Given this list of marker genes CTNNA1, SH2D1A, AHCYL2, NABP1, DCLRE1C, MTCL2, GRM8, GFM2, HAPSTR1, CDK15, HOXA9, P2RY12, GNRHR, PAWR, IBTK, SMURF1, FAM217A, CPSF6, FOXA1 (NCBI Gene Id 3169), EMX2, GRID2, TJP1, PLEKHB2, MIDEAS, NFIB, ZBTB18, NAP1L1, RNF138, DNAJC21, CBLN2, FNIP2, SLC25A35, NTS, TMEM215, WAC, ZMYND8, VAV3, ALKBH8, DTX3L, IL1A, GUCY1A2, GNPDA1, CLK4, CCND3, PRDX3, TET1, SH3RF1 (SH3 domain containing ring finger 1), MAGEE1, COQ9, STRIP1, GPR12, KLHL31 (kelch like family member 31), MBOAT1, FAM169A, ACVR2A, USO1, MCFD2, VHLL, ETAA1, ZNF491, ELOVL5, DNAAF9, ZNF677, RPL31, MED13, SOD2, CYBRD1, BEND6, TFG, PCDH19, CLSPN, SUDS3, CA5A, SMG1, MINAR1, LAMP5, SS18, C1orf52, MAP3K9, FNDC3B, SLC35B4, COL11A2, ATP2C1, TMEM68, INSIG1, RAD51B, BRINP2, FAM76A, HERC1, FZD4, SH3TC2, MINDY2, ERRFI1, RND3, PRRC2B, AGAP1, EID2 (NCBI Gene Id 163126), HPRT1, MGP, SESN3, TMEM40, MYO5C, SLC17A6, CD109, PIEZO2, SLC39A10, FAM151B, SLC9A6, ABHD6, WARS2, JAZF1 (NCBI Gene Id 94314), SCAF11, DPYSL2, EPB41L1, UBE3A, PEX11A, VSX1, TBXAS1, ATRX, MARCHF7, GRIA2, ATP13A3, IL20RA, MAP3K1, here is a description of the gene set: Human Gene Set: MIR4705 from publication Chen Y, Wang X (PMID 31504780) Genes predicted to be targets of miRBase v22 microRNA hsa-miR-4705 in miRDB v6.0 with MirTarget v4 prediction scores > 80 (high confidence targets). studied in species Homo sapiens